Given this list of marker genes ITGA6, MAP4K1, SSRP1, TTYH1, RHEB, L1CAM, KRT17, SLC6A14, APBA2, LGR5 (leucine rich repeat containing G protein-coupled receptor 5), TMSB15A, IL12RB2, GABRP, CAPN6, GART, PDZK1IP1, MICALL1, PADI2, IGKV1OR1-1, PTGFR, ITM2C, S100A1, PI3, MUC16, PRKD3, FABP7, LRP12 (NCBI Gene Id 80002), IGHV4-34 (NCBI Gene Id 28395), FGFBP1, IGHV3-7, SLC2A3, KCNG1, PTPRZ1, KLK5, ART3, CWF19L1, PTP4A3, CHRM3, PRELP, ADD2, IGKV4-1, DSG1, SLC16A1, STIP1, KHDRBS3, FNDC4 (fibronectin type III domain containing 4), PHGDH, CLDN1, ZIC1, SIX3, FZD7, USP34 (ubiquitin specific peptidase 34), AKR1C1, SYCP1, KCNK5, SLPI, MFGE8, TTLL4, KLHL7, NUP62, TNFRSF11B, IGF2BP3, PDE9A, PLA2G4A, FBXO17, FOLH1, WARS1, LTBP1, PLOD2, ARL4C, CD52, EPHX3, SCRG1, SOX9, MCL1, S100A8, TRIM29, PTPRF, TMEM45A, KLK10, IGHV4-61, CEP170, CCL20, HOXA9 (NCBI Gene Id 94575), ST8SIA1, OBP2B, LEFTY2, MIA, CA9, MTAP, TRIM2, PDPN, CHI3L2, NPRL3, CYP39A1, ZFP36L2, NPTX2, FLNA, CLIC4, TMEM158, TAGLN2, CXCL8, CLDN10, IGKV1D-39, QPCT, ACAN, NMU, YBX1, GPSM2, PEG10, PLEKHB1, CP, KYNU, TM4SF1, GJB3, IGKV3-20, ANP32E, IGLV3-19, VEGFA, GPM6B, LMO4, SOD2, FZD9, HLA-G, SOX10, BBOX1, IGHV1-69, STXBP6, KLK6, PEG3, CDKAL1, POU2AF1, OCA2, CXCL5, ENO1, YWHAE, CEACAM1, CDV3, TUBB2B, IFI16, MAGEA12, EXOC5, COL11A2, HAPLN1, KCNN4, WNT5B, S100B, NFIX, MSH6, KLF6, PSAT1, CD44, NFYC, KRT6B, DLAT, IGHG1, OBP2A, GPR19 (NCBI Gene Id 2842), PRKX, RIOK3, IL1R2 (interleukin 1 receptor type 2), GLDC, KRT81, MMP7, NDUFA4L2, MCM5, HLA-DQB2, SLC16A3, HLA-DOB, KRT23, C6orf62, BCL11A (BCL11 transcription factor A), MAGEA3, S100A2, NSD2, ACTL8, TUBB2A, SOX11, CDC5L, PRKDC, CDKN2A, CD24P4, TFAP2C, IGKV1D-13, SERPINB2, CYBA, CD24P2 (NCBI Gene Id 936), IGHV3-23, FOXO3, CALU (calumenin), CDH19, HPCAL1, DNAJB4, EN1, GALNT14, KRT83, COCH, PDK1, MRAS, FSCN1, KLK7, NKX2-5, AMD1, RBP1, IGKV1OR2-108, EIF5A, HSPD1, TFCP2L1, VGLL1, EPRS1, COL9A3, NLRP1, COL4A2, TBX19, PGBD5, DSC3, KRT14, MAGEA4, KRT6A, RYR1, WTAP, EDN1, PERP, SIGMAR1, YBX3, RRAGD, LDHB, ELN, SLC7A5, KRT5, IMPA2, SMPDL3B, CSN3 (NCBI Gene Id 1448), TDO2, IGLV2-14, PSPH, EGFR, IGKV1D-37, CTAG1B, IGKV1D-17, RAB23, BMP1, PYGB, IL32, MALL, PKP1, FERMT1, IGLV3-25, MARCO, QKI, MDC1 (mediator of DNA damage checkpoint 1), TP53, GAL, GSTM4, EPHB3, FOXC1, LAMP3, MAPK8, GBP1, CXCR4, BAG2, IGF2BP2, CD22, RAC2, PICALM, ACTG2, PRDM13, CYP26B1, IGHV3-33, PGRMC1, NFIB, PAX6, DSC2, ELF5, PRAME, AQP5, SYNM, MAGEA2, GPR161, CHST3, KLHL24, PALS2, CRYAB, KRT16, IGLC2, MAGEA5P, RARRES1, SLC43A3, ATP6V1A, GAD2, SLC25A37, SOSTDC1, LGALS2, DKK1 (NCBI Gene Id 22943), IGKV2D-28, SRD5A1, MSLN, TNFRSF21, YWHAZ, MMP14, GAGE1, COL2A1, CRLF1, PTGS2, S100A9, IGLV3-10, WWTR1, PDAP1, BGN, RUNX3, ACE2, ID4, GDI2, FYN, CASK, ROPN1 (rhophilin associated tail protein 1), ODAM, SPIB, UCHL1, SFRP1, KLF5, PTX3, WIF1, CLIP4, here is a description of the gene set: Genes down-regulated in bone relapse of breast cancer. from publication Smid M, Wang Y, Zhang Y, Sieuwerts AM, Yu J, Klijn JG, Foekens JA, Martens JW (PMID 18451135) Human Gene Set: SMID_BREAST_CANCER_RELAPSE_IN_BONE_DN studied in species Homo sapiens We explored whether the five previously reported molecular subtypes in breast cancer show a preference for organ-specific relapse and searched for molecular pathways involved. The intrinsic gene list describing the subtypes was used to classify 344 primary breast tumors of lymph node-negative patients. Fisher exact tests were used to determine the association between a tumor subtype and a particular site of distant relapse in these patients who only received local treatment. Modulated genes and pathways were identified in the various groups using Significance Analysis of Microarrays and Global Testing. Bone relapse patients were most abundant in the luminal subtypes but were found less than expected in the basal subtype. The reverse was true for lung and brain relapse patients with the remark that absence of lung relapse was luminal A specific. Finally, a pleura relapse, although rare, was found almost exclusively in both luminal subtypes. Many differentially expressed genes were identified, of which several were in common in a subtype and the site to which the subtype preferentially relapsed. WNT signaling was up-regulated in the basal subtype and in brain-specific relapse, and down-modulated in the luminal B subtype and in bone-specific relapse. Focal adhesion was found up-regulated in the luminal A subtype but down-regulated in lung relapse. The five major molecular subtypes in breast cancer are evidently different with regard to their ability to metastasize to distant organ(s), and share biological features and pathways with their preferred distant metastatic site.